Given this list of marker genes Pdk2 (NCBI Gene Id 18604), Tpk1, Pdk1, Snca, Pgk1, Pdk3, Bckdk, Pdk4 (NCBI Gene Id 27273), here is a description of the gene set: Mouse Gene Set: GOBP_REGULATION_OF_ACYL_COA_BIOSYNTHETIC_PROCESS Any process that modulates the frequency, rate or extent of the chemical reactions and pathways resulting in the formation of acyl-CoA. studied in species Mus musculus